Given this list of marker genes Sap18b, Sap18, Sart3, Rnps1 (NCBI Gene Id 19826), Acin1, here is a description of the gene set: A protein complex involved in regulation of mRNA processing and apoptosis. It binds to RNA in a sequence-independent manner and is recruited to the EJC prior to or during the splicing process. In humans the core proteins are RNPS1, SAP18 and ACIN1. Mouse Gene Set: GOCC_ASAP_COMPLEX studied in species Mus musculus